Given this list of marker genes PCDHA7, PCDHA1, ENPP2, KLF6, PCDHA9, PLP1, CRK, PCDHA10, PCDHA8, ATP5MG, TP53INP1, PCDHA11, PURB, ZFAND3, DEDD, PTEN (NCBI Gene Id 8037), SF3B4, RYBP, NLK, PCDHA3 (NCBI Gene Id 56145), OLR1, ARHGAP1, BAZ2A, PCDHA12, GAD1, PCDHA5, SMG6, PHLPP2, PCDHA2, MMP19, MMD2, PRRC2C, RAB5C, INSIG1, SELENOT, PCDHA4, PCDHA6, PCDHA13, PCDHAC1, USP47, NPAS2, OSBP, MLF1, SOX2, PBX3 (NCBI Gene Id 5090), MEIS1 (NCBI Gene Id 4211), VEZF1, PCDHAC2, here is a description of the gene set: Human Gene Set: ACCAATC_MIR509 species: Homo sapiens Genes having at least one occurence of the motif ACCAATC in their 3' untranslated region. The motif represents putative target (that is, seed match) of human mature miRNA hsa-miR-509 (v7.1 miRBase).